The following is a description of a gene set: species: Mus musculus Enables the transfer of fatty acids from one side of a membrane to the other. Fatty acids are aliphatic monocarboxylic acids liberated from naturally occurring fats and oils by hydrolysis. Mouse Gene Set: GOMF_FATTY_ACID_TRANSMEMBRANE_TRANSPORTER_ACTIVITY, and this is the list of marker genes: Slc27a6, Slc27a1, Fabp4, Fabp1, Slc22a28, Slc2a1, Slc27a2, Slc27a5, Slc22a26, Fabp3, Abcd2, Slc22a30, Fabp5, Slc22a27, Slc5a8, Abcc1, Abcd3, Abcd4, Mfsd2a, Slc27a4, Slc43a3, Slc22a19, Cd36, Slc22a29, Fabp2, Abcd1